Given this list of marker genes TRAF5, IL1B, STAT3, IL17A (interleukin 17A), MIR135A1, USP25, CXCL10, SOCS3, NOTCH1, NFKB1, IKBKE, IL17F, TRAF6, TRAF3IP2, TRAF2, IL17RA, SRSF1, NFKBIZ, TRIM32, here is a description of the gene set: Any process that results in a change in state or activity of a cell or an organism (in terms of movement, secretion, enzyme production, gene expression, etc.) as a result of an interleukin-17 stimulus. species: Homo sapiens Human Gene Set: GOBP_RESPONSE_TO_INTERLEUKIN_17